Given this list of marker genes Syk, Stat5b, Sox4, Ptprc, Gimap5, Nckap1l, Tcf7, Skint1, Lck, Stat5a, Egr3, Rorc, Lef1, Gimap3, Sox13, here is a description of the gene set: studied in species Mus musculus Any process that modulates the frequency, rate or extent of gamma-delta T cell activation. Mouse Gene Set: GOBP_REGULATION_OF_GAMMA_DELTA_T_CELL_ACTIVATION